Given this list of marker genes Ghitm, Abcb8, Serpinb2, Fgfbp1, Lhfpl2, Nnmt, Myom2 (myomesin 2), Cth, Tspan12, Prl2c2, Agap1, Htatip2, Gadd45a, Ero1a, Cd53, Vegfc, Tmem47, Rragd, Twist2, Glce, Sh3gl3, Ctla2a, Gsta2, Speer4b, Car6, Gm5169, Nap1l2, Serpinb9c, Lpl, Gsta1, Clec5a, Aldh1l2, Akr1b7, Atf5, Opn3, Xlr, Tfpi, Miga1, Ampd3, here is a description of the gene set: Down-regualted genes from the set F (Fig. 5a): specific signature shared by cells expressing AF4-MLL alone and those expressing both AF4-MLL and MLL-AF4 fusion proteins. species: Mus musculus from publication Gaussmann A, Wenger T, Eberle I, Bursen A, Bracharz S, Herr I, Dingermann T, Marschalek R (PMID 17130830) Mouse Gene Set: GAUSSMANN_MLL_AF4_FUSION_TARGETS_F_DN The reciprocal chromosomal translocation t(4;11) is correlated with infant, childhood, adult and therapy-related high-risk acute leukemia. Here, we investigated the biological effects of MLL.AF4, AF4.MLL or the combination of both reciprocal fusion proteins in a conditional in vitro cell culture model system. Several parameters like cell growth, cell cycling capacity, apoptotic behavior and growth transformation were investigated under physiological and stress conditions. Co-transfected cells displayed the highest resistance against apoptotic triggers, cell cycling capacity and loss-of-contact inhibition. These analyses were complemented by gene expression profiling experiments and specific gene signatures were established for each of the three cell lines. Interestingly, co-transfected cells strongly upregulate the homeobox gene Nanog. In combination with Oct4, the Nanog homeoprotein is steering maintenance of pluripotency and self-renewal in embryonic stem cells. Transcription of Nanog and other stem cell factors, like Oct4 and Bmi1, was verified in biopsy material of t(4;11) patient cells which express both reciprocal t(4;11) fusion genes. In conclusion, the presence of both reciprocal MLL fusion proteins confers biological properties known from t(4;11) leukemia, suggesting that each of the two fusion proteins contribute specific properties and, in combination, also synergistic effects to the leukemic phenotype.